Given this list of marker genes BUB1B, CDH11, PLAG1, FAT4, FZD2, HSD3B2, UPB1, FGFR2, SOX9, CHD7, IRF6, SRD5A2, IGF2, SEMA3E, POR, MID1, HMGA2, MYRF (myelin regulatory factor), HOXA13, CDKN1C, SRY, HOXD13, CYB5A, KIFBP, NR5A1 (nuclear receptor subfamily 5 group A member 1), SPTBN1, DHCR7, COLEC10, ZEB2, DACT1, AR, MTM1, CYP17A1, MAMLD1, SALL1, here is a description of the gene set: Bifid scrotum Human Gene Set: HP_BIFID_SCROTUM Midline indentation or cleft of the scrotum. species: Homo sapiens